The following is a description of a gene set: Human Gene Set: GSE25147_UNSTIM_VS_HELIOBACTER_PYLORI_LPS_STIM_MKN45_CELL_UP species: Homo sapiens from publication Smith SM, Moran AP, Duggan SP, Ahmed SE, Mohamed AS, Windle HJ, O'Neill LA, Kelleher DP (PMID 21220698) This study set out to identify global changes in gene expression in MKN45 gastric epithelial cells following 8 hours stimulation with 10 μg/ml lipopolysaccharide (LPS) from the gastric pathogen H. pylori. Microarray analysis was used to compare changes in gene expression between cells treated with 10 μg/ml H. pylori LPS and untreated cells at the same time point. Genes up-regulated in MKN45 cells (stomach cancer): control versus H. pylori LPS., and this is the list of marker genes: ACO1, TXNDC9, RMRP, BIN3, SNRPB2, FIS1, VKORC1L1, RLN3, PDLIM1, CHD9 (chromodomain helicase DNA binding protein 9), SNORD49B (small nucleolar RNA, C/D box 49B), PANX2, MIR491 (microRNA 491), PRKX, COX4I1, GLUL, BMPR2, TBCA, PPBP, RPF1, FAM181A, NUDT19, HSCB, AKT2, POU5F2, LSR, SCN2B, MIR503, ZBTB42, ZBED3, DGUOK, SYT7, ZNRF2, SARS1, RPL23A, SNRPC, NRGN, FNDC5 (fibronectin type III domain containing 5), RPL35A, FGF11, ANK3, DSTN, MIR17HG, NRP1, AVEN, POLR1D, ACYP2, EFNA3, APLP1, IRX1, KCNH4, CAPZB, TMEM158, LEF1, SCRT1, PCIF1, CSTF3, PROX2, ODAD3 (NCBI Gene Id 115948), STT3B, MRPS35, LYSMD2, IGF2BP3, ENTPD3, LLPH, DIP2C, DPY30, MRPL40, ALYREF, BARHL1, TSEN34, EFNB3, GCNT3, METTL9, DENND1B, ERI1, DIS3L, FBXO27, TTBK1, SDHD, NEBL, MPHOSPH6, CHMP2B, THYN1, DDX10, HNRNPUL1, LYPLA1, ARL2BP, PRDX1, HAND2, CEP350, RNPS1 (NCBI Gene Id 10921), HEXA, WFIKKN2, SNORA52, ZYG11B (NCBI Gene Id 79699), AGAP1, PRPF38A, PA2G4, RP9, VDAC3, RAB21, ZYX, PSMD13 (proteasome 26S subunit, non-ATPase 13), LY6G5C, VAPA, KLHL24, TMEM176B, VANGL2, SCNN1A (NCBI Gene Id 6337), FOXQ1, SYT6, TASP1, UBE2V1, SSBP3, PDCD1, PPP1R3E, PDCL3, CLDN3, PSMD1, SP2, PSMA2, HMBS, SUGT1, EXT2, MIR665, TSPAN6, TUBB1, UNC119, SPEM1, TRMT12, CCDC85C, RWDD4, GNG3, ZFP64, DRAM1, GRAMD2A, HMX3, SLITRK1, IP6K3, CHIC2, MCTP2, SACS, ERH, ITGA1, RNY3, CCT4, GGH, DENND4C, VWA2, RPH3AL, RPSA, FRYL, HYCC1, ELOC, ATP6V1D, KIF12, MTMR9, UBE2K, DCPS, MTCH2, PRPH2, MRPL48, CHCHD3, TRMT5 (tRNA methyltransferase 5), NXPE1, HES2, MEA1, KLHDC10, CAPNS1